Given this list of marker genes SMURF1, PSMA3, TARDBP, PRPF39, CAPRIN1, IRF7, USP10, RCN1, DENND1B (NCBI Gene Id 54530), GAS8, C1S, NMI, PSMB8, ACTR10, ATG3, USP7, GABPB1, TAP1, PRRG4, AIDA, CASP4, STAT3, CASP7, RALB, UBE2L3, RNF114, IL15RA, ASCC3, PRPF3, PCNX1, WARS1, RAB5IF, PDE6B, NIPBL, CXCL9, MVP, RAB27A, CDS1, FCGR1BP, CRYBG1, IFIH1, STAT1, RHBDF2, USO1, CHD9, NCOA3, PLSCR1, MTHFD2, GRIN2D, PLA1A, AMD1, PLAAT4, SLAMF8, TMEM185B, DUSP3, ALAS1, CDKN2AIP, PHF11, SS18L2, USP25, AKAP12, PSME2, RGL1, SRP54, CYP3A4 (cytochrome P450 family 3 subfamily A member 4), RRS1, MARCHF5, GIMAP4, APOL1, SNRNP35, CARS1, LIMK2, IFI44L, BAZ1A, DR1, MAX, VPS54, RBCK1, ENY2, RELB, RAD23A, MELK, GGPS1, PLEKHO1, TRPM4, ECPAS, PDCD1LG2, BBC3, USP15, SERPING1, STK38, FNTA, TYMP, WSB1, MCUB, NUP62, ERAP2, ETV7, GTF2E2, PRPS2, LAMTOR3, DDX60, ZC3H7A, MX1, SLC12A7, IL15, RAPGEF2, RHOBTB3, C1RL, SRI, TIA1 (NCBI Gene Id 7072), RSAD2, DSC2, IFI44, CD47, JAK2, CSF2RB, STX17, AGO3, VPS9D1, PSMA2, CFB, APOL6, FUT4, HERC6, HLA-E, BCAR3, IL32, RBMS1, SSB, WWC2 (WW and C2 domain containing 2), BCL10, WDR45 (NCBI Gene Id 11152), NOD2, C15orf39, TDRD7, ERC2, SMCO4, INTS13, SAP30L, TNFAIP2, MOB1A, RFK, GBP2, WNT5A, TNFSF10, CUL1 (NCBI Gene Id 8454), ARCN1, CXCL11, ADAR, PARP12, GK, LIG4, CD53, SLAMF7, UTP6, RBM34, APOL3, TOP1, KARS1, LRRC42, STBD1, GBP1, NOC3L, KEAP1, SLC12A8, ARAP2, APOL2, IDO1, NBN, CYLD, ELF4, SCO2, DYNLT1, NPEPPS, PSMB2, CERS6, DNAJA1, LRIF1, ACTR6, SCYL2, ARF3, C1R, PSMA4, VAMP5, SP110, CD40, CIITA, CALCOCO2, RNF24, ANKRD27, ISOC1, BIRC3, PSMB9, SNTB2, CYBC1, NFKBIE, SECTM1, LAP3, PRPF40A, here is a description of the gene set: Human Gene Set: GSE1432_1H_VS_6H_IFNG_MICROGLIA_DN from publication Rock RB, Hu S, Deshpande A, Munir S, May BJ, Baker CA, Peterson PK, Kapur V (PMID 16163375) studied in species Homo sapiens Microglial cells are resident macrophages in the central nervous system (CNS) and play a pivotal role in the innate and adaptive immune responses against microbial infections. The immune functions of microglia are regulated by a milieu of cytokines including interferon (IFN)-gamma. We here performed a series of experiments to acertain the transcriptional profile of human fetal microglial cells at 1, 6, and 24 h after IFN-gamma treatment. Primary human microglial cells were either untreated or treated with 200u/ml IFN-gamma. Affymetrix U133A chips were utilized. Four different tissue samples (B18, O, W, and Y20) were analyzed at the three time points. Genes down-regulated in comparison of microglia cells 1 h after stimulation with IFNG versus microglia cells 6 h after the stimulation.